The following is a description of a gene set: studied in species Homo sapiens The part of the cytoskeleton composed of spectrin, protein 4.1 and ankyrin. Spectrin-associated cytoskeleton is associated with the plasma membrane. Human Gene Set: GOCC_SPECTRIN_ASSOCIATED_CYTOSKELETON, and this is the list of marker genes: EPB41 (NCBI Gene Id 2035), SPTA1, SPTB, ANK3, DMTN, ANK1, SPTBN1, RHBG, SPTBN2